Given this list of marker genes H4C8, H4C2, GABPA, PRMT1, H4C3, PF4, H4C16, H4C12, H4C13, H4C9, CIB1, MYB, H4C6, H4C1, H4C11, H4C4, MIR486-1, H4C15, H4C5, H4C14, here is a description of the gene set: studied in species Homo sapiens Human Gene Set: GOBP_NEGATIVE_REGULATION_OF_MEGAKARYOCYTE_DIFFERENTIATION Any process that stops, prevents, or reduces the frequency, rate or extent of megakaryocyte differentiation.